The following is a description of a gene set: studied in species Mus musculus Mouse Gene Set: GOBP_REGULATION_OF_HUMORAL_IMMUNE_RESPONSE_MEDIATED_BY_CIRCULATING_IMMUNOGLOBULIN Any process that modulates the frequency, rate, or extent of a humoral immune response mediated by circulating immunoglobulin., and this is the list of marker genes: Fcer2a, Gimap5, Cr2, Cr1l, Trem2, Tnf, Foxj1, Ptpn6, Cd46, Cd55, C4bp (complement component 4 binding protein), Zp3r, Hpx, Nod2, Susd4, Fcgr2b, Ptprc, Gimap3, Lta